Given this list of marker genes Mrgprx2, Kmt2e, Pcyox1l, Rabgef1, Fcgr3, Pi4k2a, Lyn, Trem1, Il13ra2, Nppa, Elane, Cd84, Scn11a, Nlrp6, Ctsg, Cbl, Ddx21, Fcgr2b, Vamp8, Stap1, Fcer1g, Grp, Crhr1, Slc18a2, Sphk2, Itgb2l, Trem3, Gata1, Pdpk1, Rab44, Stx11, Ptgds, Tusc2, Ndst2, Stxbp3, Cx3cr1, Lypd10, Myo1f, F2rl1, Traf3ip2, Fcer1a, Gata2 (GATA binding protein 2), Lypd11 (Ly6/PLAUR domain containing 11), H2-T23, Ace, Mrgprb1, Lat2, Cplx2, Btk, Ptafr, Pikfyve, Irak4, Adora2b, Ighe, Ncf1, Cd300lb, Abr, Chga, Syk, Cd177, Dao, Pram1, Foxf1, Ighg1, Il4ra, Nppc, Myd88, Itgam, Adora3, Spon2, Anxa3 (annexin A3), Wdr1, Gpr15lg, Pla2g3, Ticam1, Card9, Snap23, Rigi, Lat, Mavs, Dhx36, Dnase1l3, Spi1, Arg1, Ywhaz, Fgr, Ddx1, Scnn1b, Ccl3, Rasgrp1, D6Wsu163e, Vamp2, F2, Il13, Milr1, Hmox1, Cxcl5, Fcgr4, Gab2, Lyst, Pomc, Jagn1, Snx4, C3, Cxcl1, Unc13d, Ms4a2, Il4, Fcgr1, Tyrobp, Rac2, Ighg2b, Tac4, Cd300a, Stxbp1, Nr4a3, Ptgdr, Itgb2, Bcr, Stxbp2, Dnase1, Stx4a, Kit, Pld2, Ccr2, Fes, Clnk, here is a description of the gene set: Mouse Gene Set: GOBP_MYELOID_LEUKOCYTE_MEDIATED_IMMUNITY species: Mus musculus Any process involved in the carrying out of an immune response by a myeloid leukocyte.